Given this list of marker genes AMPD2, DLX5, EN1, ONECUT2, PABPC1 (poly(A) binding protein cytoplasmic 1), STAT3, MOSPD1, MGLL, CD99L2, KRT8, NEUROD2 (NCBI Gene Id 4761), NDUFA4L2, DOC2B, GNG8, PLAC1, LOXL1, RPIA, PRICKLE1 (NCBI Gene Id 144165), ROCK1, PPP1R16B, SPACA6, TFAP4, YTHDF2, PURA, RAB25, UBE2D3, SYTL2, CHMP4B, STK40, PCGF1, NRXN3, CTAGE1, TRERF1, RASL10B, DCX, NXPH3, RTL9, ENHO, INF2, JMJD1C, DOCK4, MAST1, ASB16, ANK1, PRKACG, MAP2, ANK2, CBX4, TECPR1, TCF12, KLF13, ARHGEF10L, PTK7, ABTB2, BUD23, DAAM1, HOXB5, ENO3, LYPD1, PARP8, CDC42EP3, BMP4, HYAL2, BDNF, PAX2, HOXA11, SNX24, RAP2B, MFAP4, CDC42SE1, TCF7, ATP2B3, ACE (NCBI Gene Id 654142), CREB3L1, RIMS1, PKD2L1, PRKACA, TBX3, KCNN2, MID1IP1, MGAT1, C11orf52, SCRT2 (NCBI Gene Id 85508), ADNP, ZNF232, KMT2A, KCTD15, CNTN6, NR4A2, ZBTB16 (NCBI Gene Id 8070), ARTN, PCBP4, DLL4, KDM2A, ESRRG, PLCD3, HOXB4, IMPDH1, ZMYM4, TIMM10B, VPREB3, CAMKV, AGO1, SOX14, SMARCA5, IRF2BPL, PPTC7, PMEL (NCBI Gene Id 8088), PDGFA, OLFML2A, FOXJ2, TRIM46 (tripartite motif containing 46), YPEL4, APLN, CALM2, SALL1, FOXP1, TRIP4, CLDN5, SGMS2, ASB2, ACKR3, VSX2 (visual system homeobox 2), TMEM125, ALX3, CLINT1, MAG, PSME1, SPAG6, CDK6, RELA, LSR, SLC5A10, PTGER1, JOSD1, BCL2L2, KRTCAP2, CDK2, CHST6, CYP4V2, NR4A3, TMEM178A, C6orf62, DUSP7, NSG2, CHPF, CELF3, TNS2, ZBTB18, ZNF513, COL19A1, ZNF70, FOXP4, NLGN3, RFX8, SULT2B1, NT5DC2, CHD4, SEPTIN3, PLPP7, TSHZ3, TRAF4, VPS45, SPIB, BAHD1, FOXA1, TPM3, NDST4, HIF1A, RAB27A, GRIN2D, SIX5, KCNMA1, BRSK2, SPATC1L, GIPC1, SOST, PTPRS, MAP3K3, KCND1 (NCBI Gene Id 3750), DUSP26, ARL4A, DLL1, PDGFB, DPF3, MRGPRF (MAS related GPR family member F), SIN3A, KLHL1, FAM131A, CAPN5, CBX6, HSD3B7, DUSP9, TGIF1, MRPL14, FAM13B (NCBI Gene Id 51306), LZTS2, ARFIP2, RTKN, CALCOCO1, here is a description of the gene set: species: Homo sapiens Genes having at least one occurrence of the motif NNNGGNCNCAGCTGCGNCCCNN in the regions spanning 4 kb centered on their transcription starting sites. This matches the NHLH1 transcription factor binding site V$HEN1_01 (v7.4 TRANSFAC). Human Gene Set: HEN1_01